The following is a description of a gene set: Any process that activates or increases the frequency, rate or extent of CD4-positive, alpha-beta T cell activation. Human Gene Set: GOBP_POSITIVE_REGULATION_OF_CD4_POSITIVE_ALPHA_BETA_T_CELL_ACTIVATION studied in species Homo sapiens, and this is the list of marker genes: IL23R, XCL1, SOCS5 (suppressor of cytokine signaling 5), SASH3, NFKBID, FOXP3, CARD11, HLA-DRB3, GPR65, IL23A, MIR21, BRD4, CD80, CD28 (NCBI Gene Id 940), CD86, IL2RG, SHB, CCL19, HLX, CD81, TGFBR2, CD3E, ZBTB7B, TNFSF4, SOCS1, CD83, NFKBIZ, BRD2, EP300, IFNG, KLHL25, RARA, PRKCQ, CD55, NCKAP1L (NCK associated protein 1 like), OPA1, PRKCZ, HLA-DRB1, RIPK2, NLRP3, ANXA1, IL18, IL12B, MALT1, IL12RB1, HLA-DRA, CD160, LGALS9, IL4R